The following is a description of a gene set: from publication Nagar M, Jacob-Hirsch J, Vernitsky H, Berkun Y, Ben-Horin S, Amariglio N, Bank I, Kloog Y, Rechavi G, Goldstein I (PMID 20181891) Here we show that tumor necrosis factor (TNF) induced in human T-regulatory cells (Treg), as compared to conventional T cells (Tcon), a transcription program highly enriched for typical NF-κB target genes, such as: the cytokines LTA and TNF; the TNF-receptor super family members FAS, 4-1BB and OX-40; various anti-apoptotic genes; and other important immune-response genes. As an initial approach to examine the cellular program induced by TNF in Tregs versus Tcon cells, we employed microarray gene expression analysis at 2 and 24 hrs following TNF treatment. species: Homo sapiens Human Gene Set: GSE18893_TCONV_VS_TREG_2H_TNF_STIM_DN Genes down-regulated in lymphocytes treated with TNF for 2h: T conv versus T reg cells., and this is the list of marker genes: RRN3P2, BTBD7, FAM43A, ZNF354A, AKAP13, TRAK1, ARRDC2, ANKRD12, KDM7A, CAMK1D, PHF11, DDX17, BTN2A1, MYCBP2, ATP2B1-AS1, RAB11FIP4, DNMBP, CEP350, BACH1, C1orf162 (chromosome 1 open reading frame 162), ADAM8, MED13, ASCL2, CSRNP2 (NCBI Gene Id 81566), PPP2R5C, BTN3A1, FGFBP2, ZHX2, TAPT1-AS1, RNFT1, ZFYVE28, MS4A7, CDC42EP3, LINC02035, NXF1, TMCC3, CCDC126, BCL6, GPR155, MIR22HG, ZNF333, ZNF641, ZFP36 (NCBI Gene Id 7538), RELCH, CREBBP, DDX59, TENT5A, SNX29P2, TCF7L2, LCOR, ZNF844, CREBRF, RNF146, OGFRL1, ZNF222, PNPLA8, ZFAND5, SLC27A1, ADPGK, PIK3IP1, THEMIS2, ZFYVE16, SSH1, TLR1, TNRC6C, AMN1, PNRC1, TANC2, STAT6, ZNF91, ZBTB44, MBTD1, ZNF655, PHF12, CUL5, FBXO11, TRIM38, GIMAP8, CXCR4, PLXND1, SNX16, BRD2, MGAM, CBX7, EFR3A, ZEB2 (NCBI Gene Id 9839), KDM4C, SLC26A11, WDR19, CPD, TREM1, DLGAP1-AS1, ATP2B1, PTPRE, PLEKHM3, ACVR2A, MS4A1, LATS2, CD7, ATAD2B, YPEL5, ZBTB17, HBP1, MED13L, SERPINA1, NOTCH2NLA, OSBPL7, EPHA4, BTN3A2, SLC35A1, IST1, GOLGA7, ZNF211, ZNF148, ZNF189, BAZ2B, CNN3, LINC01138, PRKAG2, NBPF10, SMIM14, ADCY7, AFF4 (ALF transcription elongation factor 4), CCDC186, PLEK, CHST2, SERINC1, CLK4, CEBPB, CCPG1, ERBIN, ZDHHC17, JMY, BOD1L1, RESF1, HLA-A, FOSL2, GKAP1, LBH, CD27, TNFRSF14, BTG1, ARHGAP26, APLP2, TULP3, KLF3, STK4, ZNF226, MGAT4A, LIPT1, THBS1, SORL1, ETV3, KMT5B, ZNF585B, UBL3, TET2, HECA, MBD6, FNIP2, ZMAT1, FRY, ABTB1, ATP9A, TCEAL3, CSTA, PAN3, TRAPPC8 (trafficking protein particle complex subunit 8), FAM161B, SCAF4, EBLN2, PPFIA1, DAZAP2, BTN3A3, ATM, SCML1, SYMPK, MAP3K2, SDF4, AUTS2, C9orf72 (NCBI Gene Id 73205), CASTOR3P, ZNF252P, PTPN12, ZDHHC23, ZBTB18, ZNF701, TCP11L2, HLA-G, RABGAP1, PRNP, HLA-B, NLRP3, PLAC8